Given this list of marker genes CASQ1 (calsequestrin 1), VMP1, CRACR2A, ATP2A1, ASPH (aspartate beta-hydroxylase), JPH2, STAC, STAC2, HAP1, NIPSNAP2, STIM1, CACNB3, STIM2, STIMATE, STAC3, HTT, here is a description of the gene set: species: Homo sapiens Human Gene Set: GOBP_POSITIVE_REGULATION_OF_CALCIUM_ION_TRANSMEMBRANE_TRANSPORTER_ACTIVITY Any process that activates or increases the frequency, rate or extent of calcium ion transmembrane transporter activity.